Given this list of marker genes LRP5, TRIM37, LIFR, NF1, TBCE, SOST, TGFB1, FAM111A, MAN2B1, SETBP1, ANO5, COL1A1, AXIN1, here is a description of the gene set: An Abnormality of cortical bone leading to an abnormal thickness of the cortex of affected bones. Thickened cortex of bones species: Homo sapiens Human Gene Set: HP_THICKENED_CORTEX_OF_BONES